Given this list of marker genes ANXA2, ANXA2P2, LDLRAP1, MIR185, LDLR, ABCA2, PCSK9, MIR17, MIR27B, here is a description of the gene set: A receptor-mediated endocytosis process involved in intracellular cholesterol transport. Human Gene Set: GOBP_RECEPTOR_MEDIATED_ENDOCYTOSIS_INVOLVED_IN_CHOLESTEROL_TRANSPORT studied in species Homo sapiens